Given this list of marker genes CABLES1, AFP, S100G, DSG1, HOXA6 (homeobox A6), ADAMTS5, FOXP3 (forkhead box P3), TPH2, CAPN13, EREG, TRPM8, ART5, MEMO1 (mediator of cell motility 1), CYP1A1, CPEB4, EMP3, STIM2, CRCT1, TBX3, GPC6, BCO2, CP, GUCY2C, ATP1B2, MAT2A, BRAF, LPCAT3, SERPINA7, NFIB, SH3GLB2, PABPC4, SMOC1, BMP5, SPEN, CTAGE1, GTF3C1, TOGARAM1, VEZF1, CNR1, PDIA6, IL10, AGT, KLF3, SLC16A7, HOXC6, CDC73, CITED2 (Cbp/p300 interacting transactivator with Glu/Asp rich carboxy-terminal domain 2), CTHRC1, CPB1, USP26, PRIM2, GIT1, ADAMTS1, NSD2, DKK4, CX3CL1, BRCA2, CLEC4D, FOS, AGBL2, TRIM63 (tripartite motif containing 63), B3GALT4, AMDHD2, ABR, KBTBD12, OTP, IL1RAPL1, BACH2, HMGCS2, MSMB, FAM89A, HOOK1, CITED1, PACSIN3, KRT16, MGME1, ORC2, HSPB3, OPA3, BMI1, CYP7A1, UTS2, HS6ST2, SLCO1A2, STAG2, ANGPT4, SLC38A4, SYTL2, CALD1, AREG, ACE, OSBPL8, SYNE1, CYP2A7, ARAP2, SLC3A1, ZC3H10, ACTA1, DHRS11, PRL, TWIST1, LUC7L3, IGSF9B, TCF12, ATF4, SMYD1, FGF10, RAB5B, PBK, PRKACB, KRT20, ADGRD1, TRIM59, SAP18, ASB4, FOXD3, KRT33A, TEAD1, ASCL3, FURIN, CNTN4, NEFH, PROM1, RBM8A, SCGN, SEMA3C, RNF39, CCL15, PLA2G4B, SRSF7, POU2F1, CLCA4, IL2, CYP26A1, GH2, HARBI1, KIRREL2, GPBP1L1, H2BC1, RPA4, KRT10, MT4, NOS1AP, PSCA, FBLN5, FSHB, TMTC1, RHOA, THBD, MGAT3, BRMS1L, GDPD3, PEG3, HTR7, ZFP36L1, TFAP2A, KRT14, RCOR1, BEX2 (brain expressed X-linked 2), ALDH4A1, SEMA3A, SLC35B3, REG3A, IBSP, KLHL28, ACTG2 (NCBI Gene Id 72), BPI, STAG3L4, STRADB, ZNF654, ATXN7L1, SRF, PDGFB, ENSG00000255537, ZRANB1, UBE2E4P, PUM3, TAFA1, IGF1, FOXA3, CNTN1, KCNK12, RBMX, KRTAP6-2, SLC25A4, GPR153, GEN1, IL1F10, OTOP2, RTP1, PCDH8, JUNB, TMIGD1, ADCK1, KRTAP12-2, RIMOC1 (NCBI Gene Id 285636), SELE, CA4, HOXB8, KCNIP4, HOXD3, MYH4, EPX, IFT57, PRSS2, ACKR1, GEM, RIOX2, SPRR3, STC1, TBX6, KRTAP12-1, SOX2, ICAM1, TBX4, DLX1, WNT2, TG, TIGD4, TUBA4B, MID1, SLC4A9, NRP2, SAMD11, TCF4, KRT222, SOX30 (SRY-box transcription factor 30), PRSS1, DMXL1, FOXP1, DKK1, KLHDC8B, NAV3, ING1 (NCBI Gene Id 3621), PTHLH, MBTPS2, ZNF407, KCTD15, RERG, LGI1, CYCS, MTCH2, CUL3, EHD1, LTA, SLC50A1, A1CF, KCNN3, HAP1, MMP13, PHOX2B, PITX2, LYPD1, HESX1, SPOCK2, RBM14, HAND2, TNNI2, PRAC1, P4HA1, DPT, DOCK11 (NCBI Gene Id 139818), SATB2, B3GALT6, HBEGF, DNM2, RAPGEF4, GPER1, IL13, CGB3, H3C12, CD69, DLG2, TGM3, CKB, VGLL3, GPX1, S100A2, MYO18A, TCF21, NR4A3, ITGA7, PLEKHA1, RPS28, DENND2B (DENN domain containing 2B), KRT23, LRRTM3, WNK2, DSTN, PDZD2, KLHL13, KRT27, SLC30A1, FDCSP, SARNP, TMPRSS3, KRTAP19-1, VCAM1, DYRK2, APOC2, GOLGA1, HDAC9, C10orf71, RBFOX2, SLC12A3, CILK1, PTCH2, CRISP1, OGN, TMEM117, CTNNAL1, WDR82, SEPHS1, WWC2-AS2, SOCS1, UTRN, NME5, STIM1, MYH1, LHB, PTPN21, CEMIP, OLIG2, GPRC5D, IL1R2, NFIL3, LINC00649, IMPDH2, FLRT1, UQCRFS1, SRPK3, PCDHA11, MIR503HG, TRPM4 (transient receptor potential cation channel subfamily M member 4), CTCF, COL13A1 (collagen type XIII alpha 1 chain), GLUD1, TENT5A, H2BC3, MYF6, REG1A, TNFSF10, GRIN2B, S100A8, H3C3, LNPK, INHBA, EMC6, PPP1R10, OTOS, KITLG, BLCAP, KCNJ14, ANKRD30BP2, HMGN3 (high mobility group nucleosomal binding domain 3), SLC6A14, FGF5, FOXN3, CYP1A2, COCH, MYC, ENSG00000291228, GPR85, SLC26A9 (solute carrier family 26 member 9), MMP8, ENAM, IRS1, CYLD, BGLAP, NEFM (NCBI Gene Id 4741), TRMO, CEP95, REG3G, JPH1, H2AC13, FOXA1, KRTAP13-4, GALNT7, KRT36, TRAK2, DIAPH3, CDKN2C, SPTAN1, TES, LHX5, PRDM1, TSHB, XPO4, APOA5, ACTB, RFX4, OPN1LW, MOS, RPLP0, MMP23A, LBX1, KRT73 (keratin 73), TBCC, SERPIND1, USP16, UBE2B, CEBPB, ETV1, COL19A1, ITGB3BP, MID2, OGFOD1, CCL5, COL11A2, HOXB5 (NCBI Gene Id 3215), MLIP, SPTB, IKZF4 (NCBI Gene Id 64375), CCDC88A, SHOX2, SDR9C7, CELF4, LRMDA, NCALD, GALNT3, MYPN, SLC9A5, NOS1, C2CD4A, TGFB3, ZNG1B, CCDC140, AMELX, CHRDL1, GSC, SULT2A1, ZNF827, KRTAP13-3, USP47, NPC2, RPF2, MGST3, SRSF8, PMP2, ALDH1A2, SLC35C2 (NCBI Gene Id 51006), ACTN2, TUBA4A, LGALSL, MYCT1, IL1RN, GABRB2, CD24, BCL6 (NCBI Gene Id 604), MYH2, NR0B2, SNX21, RCN3, ARFIP1, H3C10, FLI1, CHMP1B, UTY, MPC2, EMSY, SLC2A3, UCHL1, NHS, ABLIM1, DNASE1L3, NOS2, IGFBP4, ID3, LMO2, TRDN, CSNK1E, MYLK, LPO, PLEC, BMPR1B, FYN, AMELY, ESRRG, CSF3, CRYBA2, CAB39L, ELAVL3, RUNX2, CCNG1, BHLHE22, ZBTB10, TRPV6, HNRNPAB, GDF15 (NCBI Gene Id 9518), TPM3, SOX3, RNF207, CHD2, PADI4, MSS51, EIF4A2, PRKG2, CNTN6, KLF3-AS1, LPL, KRTAP4-7, YRDC, SRSF3, RARG, IRAK1, KRT25, PPARGC1A, PAX3, RRAGB, RGS4, MPP4, PEX3, PHF20L1, FLT1 (NCBI Gene Id 2321), KRTAP21-2, TSPEAR, TAX1BP3, CHM, P2RX5, DNAJC1, COLCA1, TSC22D3, SRSF2, CBLN4, KLF14, TNNT1, GSTM3, LAPTM5, RRM2B, SESTD1, PATE1, ZBBX, HOXC5, EPN1, USH1G, HSPA13, CCL4, ZNF691 (zinc finger protein 691), RBMS1, PPP2R2A, ID1, SSH3, SOSTDC1, ANKRD23, MEOX2, INS, SLC26A7 (solute carrier family 26 member 7), MSTN, KRT35, CELF3, TSPAN9, AGTR1, GAPDH, TSC22D1, SUMO4, NDST3, NEXN, PART1, OFCC1, TSPAN12, PPP1R3A, TULP4, LRR1, SRGAP2, EGF, RPS19, STK3, ESM1 (NCBI Gene Id 11082), ATXN1, CPNE1, CD36, NR2F1, DCDC1, SLC29A3, TOP2A, CYP20A1, CRBN, ZIM2, CGB7, VIT, NDST4, ZUP1, FGF16, DMD, AQP3, POU4F3, HOXA2, ZKSCAN5, LYSMD2 (NCBI Gene Id 256586), AOC2, PDK4, CDX1, G0S2, DSPP, CYP26B1, MYH8, PRPS1L1, C6, RTL3, MMP7 (NCBI Gene Id 4316), GLIS3, FN1, HOXA9, ANKRD39, TMEM62, ZNG1A, PUM2, ECI1, TIGD3, SECISBP2L, ADGRB3, GLRA2, PNMA1, SPRR2B, H2AZ1 (H2A.Z variant histone 1), HRC, POU4F1, OPHN1, LCE5A, GTF2A1 (NCBI Gene Id 50857), ABCG2, ENTHD1, PRLHR, CTLA4, PTPRD, SEMA4B, CSDE1, AKAP8L, TBX20, ID2, CLRN3, CIPC, IGSF21, PPP2R5E, HOMER2, HERC1, SELENOP, STPG4, ELMO3, CRTAC1, CCDC3, HOXC12, NRAS, XK, KDM6A (lysine demethylase 6A), STAC, PPP2R3C, COMMD3, LEFTY2, WIF1 (NCBI Gene Id 11197), GH1 (growth hormone 1), C19orf48P, ARRDC3, TCF7, CALR, S100A4, PRDX1, AIG1, PKP1, SLC5A7, BNIP3, EBP, LCN1, SKAP2, H1-3, INVS, CCDC85B, TACR1, RNF148, HMGCS1, SULF1, ITPKC, XRN1, LSM5, RNF17, H3-4, MMP20, MYH13, SEMA6D, NPPC, RLN3, H1-1, SKAP1, ADK, ARL4D, NRN1L, MTUS1, INSM2, MFSD6, FCRLA, ZNF711, CLEC3A, S100A9, IL17F, ELMO1, TSGA10, SCARF1, CACNG2, NPY5R, WBP4, GARRE1 (NCBI Gene Id 9710), CNTLN, SLC35D1, NPPA, FST, HOXC4, KLHL40, DUOXA2, CGB8, EPHA7, DDIT4L, KRTAP9-2, CSRNP3, PA2G4, TRPC4, FBXW11, H4C1, KRTAP8-1, HFM1, LRRN4CL, MRPS18B, EGR2, TMEM178A, C1QTNF3, INSL5, LIF, ITIH6, H2AC20, FAM133A, NCOR1 (NCBI Gene Id 9611), VGF, RBMXL2, B3GLCT, HARS2, LYPLAL1, ZBTB20, TECR, POFUT1, LYRM2 (LYR motif containing 2), IRX4, FEV, NR2F2, ABCA1, HMGN2, MS4A14, MMP23B, MAP4K4, NNT, PARP16, VIP, ART3, ABCC6, TM4SF4, ZBTB9, DIS3L, TPM2, NKIRAS2, MEIS1, CA2, MAB21L1, MBD3L1, SEMA4C, MOSMO, PCBP1 (poly(rC) binding protein 1), TRPM7, G6PC1, MIA2, RGS3, TRIM2, CSHL1 (chorionic somatomammotropin hormone like 1), CYYR1, LPAR4, H2AC1, LHX6, SENP8, KRTAP6-1, AGPAT4, KRTAP20-2, BICD1, SRSF6, LY6G6C, CSH1, MAP3K13, OSR2, CADM1, GRHL2, NPVF, APOBEC2, NEK10, KRT17, ADAMTSL2, SMG6, PAPPA, THAP8, SLC25A27, EN1, LUC7L, MSC, TMEM88, CELA1, ASIC2, ARHGEF2, PI15, AFM, TNF, NDRG2, ZNF516-DT, S100PBP, CCN1, ANGPTL1, LEFTY1, PRPH, PDGFC, GJA10, HPSE2, CCDC138, SCUBE3, PAIP2, COL10A1, UBE2S, SPRR1A, H2BC8, SIM1 (SIM bHLH transcription factor 1), TNMD, MMP10, LINC01597, CARF, ACTR3, MID1IP1, PIAS1, TSPAN13, ARMC2, BRS3, EEF2, SPINK7, RAI2, TMTC2, PABIR1, HARS1, DNAJC7, SLCO2A1, KRTAP11-1, ZIC5, ADAM10, TMEM86B, LCP1, TNKS, CGA, EDC4, COX7A2, PRKAA2, TFAP2B, EID1, PCGF5, ZIC3, P2RY12, DCX, LEAP2, CTNNA2, AQP1, KCTD8, PMCH, GFRA1, UBE2H, CLRN1, KRTAP12-3, KAT7, IL17A, MYH6, ISCA2, EDN1, SCN8A, ANGPTL4, HS3ST4, EOMES, TMCC1, TANK, TSLP, CRNN, TFDP2, KRT31, TSHZ3, SULT1B1, H3C1, SOX9, KRTAP6-3, STXBP4, HOXA11, RPA3 (NCBI Gene Id 6119), ZBTB18, HDAC7, MEIS2, HNRNPA0, ESR2, FAM118B, ANKS1B, CCDC71L, FARP1, SCAMP3, ASB5, LGSN, CLN5, KRT8, FERD3L, NEUROD6, KRT33B, ABCB1, RGS1 (regulator of G protein signaling 1), TCTA, ZRSR2, TBL1XR1, RND3, KLHL1, RIT1, SPTA1, SYT7, HAPLN1, TLK1, MACO1, CDIN1, RBBP9, ANXA1, CLUAP1, CPNE3, SKIDA1, MON1A, CELF1, TLE4, MAPRE1, CYP39A1, OLIG3, HOXD11, DNAJA4, RGS13, SCHIP1, WSB2, ADAM11, MITF, MAPK8, SLITRK2, TLE3, TENM1, PLOD2, CDH20, TMEM182, SPRR2A, MT3, CCL7, CHCHD7, ATL3 (atlastin GTPase 3), POU1F1, ASIC5, CHAD, NDP, RASSF2, NDUFA7, CA7, DMPK, C17orf58 (chromosome 17 open reading frame 58), RUNX1T1, DES, ZNF423, LECT2, HOXA10 (NCBI Gene Id 3206), H2AC8 (NCBI Gene Id 3012), NEU2, CLEC1A, INO80, MAP1B, RORA, MMP19, WFIKKN2, STEAP4, PPBP, H2AC12, HIVEP3 (NCBI Gene Id 86368), CRABP2, PLTP, DEPDC7, IL22, PRKACA, OVCH2, EYA1, CYP2E1, SNAP25, CLDN17, CCDC43, IFNG, ATOH7, SOBP, COL8A1, H2BC21, HCRT, ASB18, MPIG6B, GORAB, FGF21, SLF1, ZNF143, PSAP, HOXB3, ADGRL1, NR5A2, DKK2, NMT1, NR0B1, DIO3, RAB3A, SLCO3A1, SPINK5, TBXAS1, ASB16, SRR, KRTAP12-4, PPY, OR2K2, LRFN5, EIF3J, JPT2, CSNK1A1L, ZNF436-AS1, PROK2, FZD8, SYNE2, FAM110D, ABI3BP, MIP, DCAKD, CREM (NCBI Gene Id 1390), DEFB1, SOX5, HNRNPD, SCN3B, NFKBIA, BDNF, C8A, ARFGEF1, MMP3, HNF1A, PPARG, THBS2 (NCBI Gene Id 7058), PNLIP, ABCC5, ZMYND8, MPPED2, FGF8 (NCBI Gene Id 2253), C1orf122, PLXNA2, ELAVL2, LIN54, PATZ1, MAF, CHRM2, HOXD9, KCNMB3, KCNJ13, SLC34A1, RARA, ZG16, SCRT2, CHRNB1, SNX5, PMEPA1, PRDM12, SERPINB13, ATP5MC2, MYOC (NCBI Gene Id 4653), NAP1L3, SLC27A2, PDLIM3, RASAL2, RNF43, SLC2A4, GPRASP3, FABP6, SLC37A4, RRH, ACTC1, DMBT1, HSPB7, KRTAP17-1, CRH, PAK6, RORB, TNRC6A, LRRFIP1, PNLIPRP2, APOD, PCDHGA11, DIO2, GADL1, PCYT2, FAM81B, ELF1, FOSL2, MYH11, MAB21L2, MAN1C1, CLCN1, PPP1R15A, PCYT1B, H3-3B (NCBI Gene Id 3021), KRT76, GRP, TNFRSF25, SERPINE1, GBE1, MACIR, ATG13, FHL2, DUOX2, ATP1B4, HAVCR2, MASP1, POLE4, MGP, TGIF1, SH3BGRL3, RHOBTB1, GDNF, RTL9, PENK, RABEPK, HOXB4, PRKAG1, TGFB2, COL1A2, COQ8B, PTH, CDIPT, CDC42EP3, TBPL2, H2AC21, PRMT3, COL1A1, ENPP2, TNFRSF17, SLC2A1, TEF, LIX1, RHO, SEMA6B (NCBI Gene Id 56991), CUX1, DDX5, WDR62, MLH3, RBP2, JPT1, H2BC5, IRS4, POSTN, CYP2C18, TNFAIP8, NAT8L, HECA, GRIK4, WIPI1, ALDOB, CXCR4, RABL6, NTF3, MBD6, RXFP2, CYP26C1, RBP4, MARCO, PCF11, FGD4, ECM1, CGB2, MYOCD, TAF7L, CTNNA3, PPP2R1B, TTC17, CCL23, C8orf82, CD96, LAMP5, PDZRN4, LINC00310, ANK3, PLAGL2, SP8, ATP6V1B2, FGFBP3, NHLRC2 (NCBI Gene Id 54835), REG1B, PRPSAP2, GKN2, TRAF7, AGR3, ZNF334, MAP9, KRTAP19-7, ARF6, ANGPT1, CFL2, FOXP2, VMO1, RAD17, MAP2K5, ARPC2, MYH3, KRT26, RASL11B, SERPINB2, HTN1, SPEM1, FXYD1, CNN1, HSD3B7, GABRA1, IVL, EFEMP1, MYO3B, PLAG1, FBXO36, CPA4, MAP2K6, CRYGS, DIRAS1, ORM2, PGC, ZNF385B, C5orf46, NKX2-8, CFTR, NANOS1, LINC00670 (NCBI Gene Id 442761), PDIA4, MYL1, GCG, OTX2, HOXB6, POU3F2, KRT86, SORCS1, LINC03124, TSC1, PPP1R12A, CYSLTR1, LDB2, AMPD1, KLHL41, ZNF436, OTOF, MANF, BLOC1S4, FAM117A, LYG2, UCKL1, IFNB1, KCNH2, SYT9, TDO2, CRYBA1, SUPT4H1 (NCBI Gene Id 6827), CSH2, MYB, H4C4, BNC2, GJB1, APCDD1L, CREBRF, ADTRP, VANGL1, PRM2, SMAD9, CREB5, SYMPK, CYP2A13, NEDD4, CDX2, RNF19B, NOG, ETV5, SP6, GRID2, H2BC12, PANK1, STMN2, NIPBL, ZZZ3, OMG, EBF2, CYP2A6, VCPKMT, FAM78A, BPIFA1, FGF14, RASGRP3, CNGB3, CCN2, ERO1B, BBS1, DCLRE1A, ECT2, FABP1, SNX6, KRTAP21-1, BLK, RBM12, APOLD1, KRTAP13-1, H1-4, PSMA8, GTF2A1L, TENM3-AS1, JAM3, KRTAP10-3, KRT28, PURA, LRP2BP, ORAI3, TOB1, GEMIN8, NR4A1, here is a description of the gene set: studied in species Homo sapiens from publication Xie X, Lu J, Kulbokas EJ, Golub TR, Mootha V, Lindblad-Toh K, Lander ES, Kellis M (PMID 15735639) Genes having at least one occurrence of the highly conserved motif M51 TATAAA in the regions spanning 4 kb centered on their transcription starting sites. This matches the TAF, TATA transcription factor binding site V$TATA_01 (v7.4 TRANSFAC). Comprehensive identification of all functional elements encoded in the human genome is a fundamental need in biomedical research. Here, we present a comparative analysis of the human, mouse, rat and dog genomes to create a systematic catalogue of common regulatory motifs in promoters and 3' untranslated regions (3' UTRs). The promoter analysis yields 174 candidate motifs, including most previously known transcription-factor binding sites and 105 new motifs. The 3'-UTR analysis yields 106 motifs likely to be involved in post-transcriptional regulation. Nearly one-half are associated with microRNAs (miRNAs), leading to the discovery of many new miRNA genes and their likely target genes. Our results suggest that previous estimates of the number of human miRNA genes were low, and that miRNAs regulate at least 20% of human genes. The overall results provide a systematic view of gene regulation in the human, which will be refined as additional mammalian genomes become available. Human Gene Set: TATAAA_TATA_01